Given this list of marker genes Muc4, Ppp3cb, Smad7, Klrd1, Dusp22, Il7r, Ceacam1, Ufl1, Pdcd1, Spn, Arg1, Slamf1, Foxp3, Il20rb, Tbx21, Clec4g (C-type lectin domain family 4, member g), H2-M3, Nckap1l, Cd80, Ptprc, Ifnb1, Lilrb4a, Hfe, Vsir, Lilrb4b, Il4i1, Nod2, Ahr, Cd274 (NCBI Gene Id 60533), here is a description of the gene set: species: Mus musculus Mouse Gene Set: GOBP_NEGATIVE_REGULATION_OF_T_CELL_MEDIATED_IMMUNITY Any process that stops, prevents, or reduces the frequency, rate, or extent of T cell mediated immunity.